Given this list of marker genes Cd6, P2ry10, Ptprc, Themis2, Slfn1, Pdcd1, Fam78a, Cyp4v3, Cd160, Ccr8, Gpr68, Cd3g, Gpr33, Adora3, Gbp9, Havcr2, Syk, Igtp, Htr7 (5-hydroxytryptamine (serotonin) receptor 7), Serpina3g, Rasgrp1, Hk3, Qpct, Il18bp, AB124611, Marchf1, Rnase6, Ikzf1, Slc7a8, Rnf213, C1ra, Gimap7, Il2rg, Clec2i, Cd48, Csf2rb2, Dnase1l3, Gpr174, Myo1g, Gpr171, Ptafr, Scimp, Fgr, Il2rb, Il27, Acod1, Cd180, Naip5, Klrd1, Ifng, Ly6c1, Gimap3, Skap1, Klre1, Stat1, Lag3, Kynu, Fgl2, Serpina3f, Slfn5, Itk, Igsf6, Cybb, Ifi209, Klrb1c, Klra9, Snx20, Cd28, Ifi207, Gpr15, Nlrp1a, Gpr65, Plbd1, Mefv, Klrc1, Parp9, Cst7, Nlrp1b, Cd96, Dram1, Klra8, S1pr4, Ms4a4d, Pglyrp2, Klrb1b, Zap70, Hrh2, Slco3a1, Sh2d2a, Lat, Prr5l, Ptpro, Cd7, Trim30d, Ikzf3, Gpr18, Cd8a, Tnfrsf4, Ipcef1 (interaction protein for cytohesin exchange factors 1), Irf4, Klrk1, Gpr141 (G protein-coupled receptor 141), Sash3, Gimap8, Cd274, Hck, Cd2, Xcl1, Epsti1, Pstpip2, Tspan32, Clec12a, Dtx3l, Il2ra, Cxcr6, Stx1b, Txk, Ctsw, Cd5, Clnk, P2ry14, B2m, Il10ra, Arhgap15, Evi2, Klrg1, Tbx21, Aoah, Tnfrsf8, Gbp2, Cd300ld, Gbp5, Lax1, Pik3cg, Pirb, Tarm1, Klri2, Cnr2, Pira2, Slamf7, Ly6i, Gbp6, Ifi47, Atp8b4, Nfam1, Cd300lf, Fasl, Evi2b, Prcp, Trpm2, Parvg, Slamf8, Mmp25, Stat4, Irf1, Rassf2, Klra7, Ticam2, Klrc2, Lacc1, Xcr1, Sh2d1a, Heatr9, Foxp3, Pdcd1lg2, Rhoh, Ifi205, Cd69, Il21r, Itgal, Was, Fcer1g, Ciita, Nkg7, Tlr12, Parp14, Tapbpl, Icos, Il12rb2, Gpr132, Arl5c, Eomes, Gimap4, Cysltr2, Gbp8, Klra2, Cd244a, Card11, Cd226, Cd27, Map3k8, Irf5, Gimap1, Slamf6 (NCBI Gene Id 80894), Il12b, Cd8b1, Tnfsf14, Klra1, Tbc1d10c, Lta (lymphotoxin A), here is a description of the gene set: Most patients with cancer are refractory to immune checkpoint blockade (ICB) therapy, and proper patient stratification remains an open question. Primary patient data suffer from high heterogeneity, low accessibility, and lack of proper controls. In contrast, syngeneic mouse tumor models enable controlled experiments with ICB treatments. Using transcriptomic and experimental variables from >700 ICB-treated/control syngeneic mouse tumors, developed a machine learning framework to model tumor immunity and identify factors influencing ICB response. Projected on human immunotherapy trial data, found that the model can predict clinical ICB response. further applied the model to predicting ICB-responsive/resistant cancer types in The Cancer Genome Atlas, which agreed well with existing clinical reports. Mouse Gene Set: ZENG_GU_ICB_CONTROL_METAGENE_8_PRECICTIVE_ICB_RESPONSE from publication Zeng Z, Gu SS, Wong CJ, Yang L, Ouardaoui N, Li D, Zhang W, Brown M, Liu XS (PMID 36240281) Metagene derived from the control samples, found to be predictive of immune checkpoint blockade treatment response, not otherwise discussed. studied in species Mus musculus